The following is a description of a gene set: from publication Chen Y, Wang X (PMID 31504780) Genes predicted to be targets of miRBase v22 microRNA hsa-miR-744-5p in miRDB v6.0 with MirTarget v4 prediction scores > 80 (high confidence targets). species: Homo sapiens Human Gene Set: MIR744_5P, and this is the list of marker genes: ROR2, RGMA, PELI3, NFIX, HS6ST1, ADAP2, SURF4, BIN1, IQSEC2, ORAI2, FBLN2, SEPTIN2